Given this list of marker genes Aars2, Rtca, Rcl1 (RNA terminal phosphate cyclase-like 1), Lig4, Rtcb, Lig1, Aars1, Rlig1, Lig3, here is a description of the gene set: Mouse Gene Set: GOMF_LIGASE_ACTIVITY_FORMING_PHOSPHORIC_ESTER_BONDS Catalysis of the joining of two molecules, or two groups within a single molecule, via a phosphoric ester bond, with the concomitant hydrolysis of the diphosphate bond in ATP or a similar triphosphate. species: Mus musculus